Given this list of marker genes Slc25a26, Pgpep1, Atf7ip, Osbpl1a, Svs3b, Ap3b2, Ptms, Carm1, Tgfbr1, Nqo2, Smtnl1, Nedd8, Mamdc2, Taok1, Zfp180, Tmx4, Triap1, Sptssb (NCBI Gene Id 66183), Celf2, Nectin3, Adam1a, Svs3a, Pcnx1, Zfp641, Atp6v1b2, Aldh1a3, Ffar3, Ago1, Dcaf8 (DDB1 and CUL4 associated factor 8), Kif9, Bhlhe40, Mapk8ip3, Itga4, Zbtb34, Dtna, Aldob, Hspa12a, Riok3, Epha10, Baz2b, Znrf1, Coq10a, Amot, Wwp1, Setd7 (SET domain containing (lysine methyltransferase) 7), Pkd2l2, Grin2b, Rfwd3, Slc66a3 (NCBI Gene Id 97797), Pramel7, Mettl25b, Ebag9, Atxn2l, Pik3cd, Gm4922, Stx8, Olr1, Alk, Cnst, Csta1, Gpm6a, Iqgap2, Rps6ka2, Zcchc3, Trps1, here is a description of the gene set: Mouse Gene Set: MIR_7063_5P species: Mus musculus from publication Chen Y, Wang X (PMID 31504780) Genes predicted to be targets of miRBase v22 microRNA mmu_miR_7063_5p in miRDB v6.0 with MirTarget v4 prediction scores > 80 (high confidence targets).